The following is a description of a gene set: Arteriovenous fistula An abnormal connection between an artery and vein. Human Gene Set: HP_ARTERIOVENOUS_FISTULA species: Homo sapiens, and this is the list of marker genes: COL3A1, RASA1, EPHB4, ENG, COL1A1, COL5A1 (NCBI Gene Id 1289), ACVRL1 (NCBI Gene Id 94), COL5A2 (NCBI Gene Id 1290), PIK3CA, GDF2, AGGF1, SMAD4